The following is a description of a gene set: Human Gene Set: MIR4678 from publication Chen Y, Wang X (PMID 31504780) Genes predicted to be targets of miRBase v22 microRNA hsa-miR-4678 in miRDB v6.0 with MirTarget v4 prediction scores > 80 (high confidence targets). studied in species Homo sapiens, and this is the list of marker genes: CPEB2, COL27A1, PLD5 (phospholipase D family member 5), GALNT4, CRBN, ERLIN2, TNRC6C, SYT1, NAP1L1, MYO5C, UMAD1, GPR155, POU2F1, C11orf97, SPCS2 (NCBI Gene Id 9789), DCAF4L2, NSL1, DDTL, USP44, CCNG2, TMC7, FNDC3B (fibronectin type III domain containing 3B), WAPL, PHYHIPL, TRAT1, JCAD, PCK1, SNX5, TLR4, CREM, CELF4, DOCK3 (NCBI Gene Id 1795), DPY19L1 (dpy-19 like C-mannosyltransferase 1), ITGA8, ADAM9, ZNF225, DMAC1, TMEM170B, FAM200B, RELN, STARD3NL, TVP23C, ONECUT2, ANLN, TMEM9B, PROS1, RICTOR, RUFY3 (RUN and FYVE domain containing 3), CLDN12, REDIC1, CCSAP (NCBI Gene Id 126731), C5orf47, WDFY3, DHX16, ZCRB1, FHIT, MRPS33, TRPC5, FHAD1, UBL3, GADD45A, TRMT13, MYCN, SETD9, FMC1-LUC7L2, LHFPL5, DICER1, CCDC71L, LUC7L2, GLIPR1L2, HECTD2, MAP3K20 (NCBI Gene Id 51784), ARID3B, ATG7, ZNF462, DVL3, PPP1R3A, ZNF605, CFAP300, SMAP1, DUSP1, SLC35F1, PPARGC1B, CYP7B1, RAI2, GLMN, EYA3, DCAF10 (DDB1 and CUL4 associated factor 10), VPS37A, PIK3C2A, ELF1, CCND2, GHR, NRARP, POC1B-GALNT4, C9orf40, ZNF334 (zinc finger protein 334), CHEK1, GNG2, TBC1D8B, TSR2, ZNF695, DOCK5, WAC, FARP1, PFKP, SCYL3, AQP11, MFSD8, TTLL7, MBNL3, MBD2